Given this list of marker genes Spon2, Mre11a, Atg5, Sfn, Trim30d, Serpinb1a, Ifit3, F2rl1, Gm4841, Ifnk, Fosl1, Ccl20, Il23a, Dapk1, Trim28 (tripartite motif-containing 28), Rnf170, Nploc4 (NPL4 homolog, ubiquitin recognition factor), Fgb, Lgr4, Gkn2, Ciita, H2-M3, Csf1, Cyld, Lats2, Defb2 (NCBI Gene Id 13215), Trim12a, Stx8, Traf4, Casp4, Oas1f, Ccl21a, Ly9, Defa3, Ifitm2, Oas1e, Cnpy3, Trp53, Gm13277, Pim1, Ifi203-ps, Slamf1, Cd2, Gzmc, Cited1, Reg2, Fpr-rs6, Gm12250, Ighg2c, Ighg1, Ifit3b, Defa25, Vamp8 (vesicle-associated membrane protein 8), Serping1, Cd300ld3, S100a9, Rpl30, Dus2, Fpr-rs4, Klrb1, Ccl12, Calhm6, Phb1, Rel, Klrh1, Mapkapk2, Vip, Dpp4, Wfdc13, H60b, Was, Aqp4, Cdc42, Adar, Stxbp4, Trim8, Stxbp1, 9930111J21Rik1, Hmgb3, C1qb, Ifna1, C9, Wfdc21, Trim30a, Esr1, Actg1 (NCBI Gene Id 230535), Aim2, Cd160, Ifnl2, Map4k2, Nr1h3, Mcoln2 (NCBI Gene Id 99673), Ifna7, Il17f, Pld4, Il18rap, Tlr12, Ifi211, Serpinb9, Mul1, Tspan6, Nlrp10, Trim39, Stx4a, Kif5b, Rnf185, Sertad3, Cgas, Slc15a3, Lyar, Ube2l6, Rnf19b, Mx1, Trim62 (NCBI Gene Id 67525), Fasl, Neurl3, Myd88, Defb21, Klri1, Hc, Bpifb1, Cd300c, Dnaja3, Il33, Tmem33, Defb20, Trim38, Defb37, Ube2k, Ythdf3, Trim56, Sin3a, Ly86, Ifnab, Adam8, Defa5, Reg3d, Colec10, Rpl39, Stat5b, Slc19a1, Raet1d, Rnf39, Plscr1, Bcl3, Trim6 (tripartite motif-containing 6), Cd55b, Plcg2, Ccl19-ps1, Ifi205, Med1 (mediator complex subunit 1), Oas1d, Defa30, Trim31, Trim12c, Hmgn2, Slpi (NCBI Gene Id 20568), Gapdh-ps15, Sh2d1b2, Jak3, Slc30a8, H60c, Isg20, Defa23, Ubl7, Cadm1, Irgm2, Padi4, Defa34, Ang5, Akap8, Hk1, Tnfsf4, Ripk2, Inava (innate immunity activator), Nlrc3, Rnase2a, Lgals9, Evpl, Defa26, Rnf115, Serpinb9g, Ear14, Lats1, Gper1, Klrk1, Unc13d, Gm5849, Ccl2, Ifna11, Daxx, Nlrp9a, Ighm, Otop1, Slc15a4, Wfdc15b, Raet1e, Tirap, Ifi47, Rtn4, Tslp, Nlrp6, Appl2, Ap3b1, Pglyrp3, Irf8, Sdhaf4, Lyn, Pspc1, Tyrobp, Gm5431, Kctd9, Arg2, Oas3 (NCBI Gene Id 246727), Dhx58, Txk, Ifi208, Tlr9, Wfdc3, Bpifa1, Ptpn6, Ccl27al, Polr3h, Bspry (B-box and SPRY domain containing), Wfdc12, Cd177, Ifng (NCBI Gene Id 15978), Krt16, Trim25 (tripartite motif-containing 25), Pik3ap1, Ccl26, Slc15a2, Cebpg, Ang2, Trim15, Rarres2, Oas1b (NCBI Gene Id 23961), Cxcl9, Rfpl4, Defb40, Gramd4, Plpp6, Otulin, Rsad2, Sfpq, Clec4d, Gfi1, Rab2b, Trim43b, Ifna12, Pik3cd, Siglecg, Vamp4, Krt6a, Cybc1, Zdhhc9 (NCBI Gene Id 208884), Defa2, Setd2, Oasl1, Defb22, Gm13272, Atat1, Wfdc11, Tnfrsf14, Igf2, Ifnlr1, Rnf34, Smim30, Fga, Klrc2, Defb8, Calm1, Cd274 (NCBI Gene Id 60533), Clnk, Ipo7, Dhx33, Rnaset2a, Kynu, Tbkbp1, Gbp8, Trim75, C1rl, Akirin2, Clpb (ClpB caseinolytic peptidase B), Cyba (NCBI Gene Id 13057), C2, Peli3, Mst1r, Fgg, Rnase4, Rad50, Pla2g6, Irf1, Pqbp1, Ddx1, Romo1, Trim30c, Krt1, Letmd1, Crp, Tbk1, Usp29, Gbp3, Gimap3, Hspd1, Cxcl11, Defb39, Csnk1a1, Kng1, Evl, Cxcl5, Bpifa5, Defa42, Ifna2, Clec4n, Nck1, Hexim1, Usp50, Ppp2r3c, Ccl11, Mid2, Bpi, Usp17le, Phb2, Cstdc2, Trim41, Il21, Gzmb, Lrrc14, Cpt1a, Tlr1, Vnn1, Gpr146, Tmem43, Vamp3, Nlrp1a, Ctsg, Naip6, Erbin, Gm13271, Trim61, Lrch4, Serpinb9d (NCBI Gene Id 20726), Cd300e, Sftpd, Pla2g2f, C1s1, Nfkbiz (nuclear factor of kappa light polypeptide gene enhancer in B cells inhibitor, zeta), Klk7, Ifngr2, Ear2, Gimap5, Zdhhc12, Hmgb2, Atg14, Ttll12, Pglyrp4, Sp110, Nod2, Fadd, Matr3, Nfkbia, Ilrun (NCBI Gene Id 98074), Defb42, Polr3g, Lsm14a, Brcc3, Gapdhrt, Xcl1, Otud4, Nlrp9c, Arid5a, Defb11, Csf1r, Defb1 (defensin beta 1), Edn1, Nlrc4 (NCBI Gene Id 271473), Hrg, Mpeg1, Gp2 (glycoprotein 2 zymogen granule membrane), Cfhr4, Rnf135 (ring finger protein 135), Zdhhc3, Rnase6, Pf4, Defa31, Ifi206, Tab1, Dtx3l, Ipo5, Ywhaz, Cd1d2, Vim, Gbp2, Rab43, Tfeb, Lag3, Apobec3, Gimap6, Slc11a1, Mmp7 (NCBI Gene Id 17393), Ighg2b, Samhd1, Hsp90aa1, Gdi1, Nos2, Polr3d, Trim68, Ifna6, Abhd17a, Ccl19-ps5, Mst1, Cfh, Tgfb1, Tlr2, Sp100, Mavs, Banf1, Ffar2, Cdc37, Spi1 (Spi-1 proto-oncogene), Trim30b, Trf, Mapk8, Ptpn22, Cldn2, Srebf1, Defa29, Sqstm1, Trim55, Kcnj8, Slamf8, Kif16b, Ifne, Trim26, Nlrc5, Grb2, Lep, Usp20, Tnfaip8l2, Reg3b, Nppb, Gm12185, Mill1, Tlr11, Hamp2 (NCBI Gene Id 66438), Zfp809, Cdc42ep4, Fau, Lacc1, Leap2 (NCBI Gene Id 259301), Masp1, Kcnk13, Rasgrp1, Nts, Fcer1g, Serpinb9e, Susd4, Zbp1, Hdac4, Cxcl12, Endod1, Ticam2, Cd226, Tac1, Chuk, Rnf144a, Ccl19-ps4, Defb29, Trim32, Stxbp3, Pik3r1 (phosphoinositide-3-kinase regulatory subunit 1), Ogt, Riok3 (RIO kinase 3), Eprs1, Gbp9, Trim43a, Ccl5, Traf3ip3, Irf2 (interferon regulatory factor 2), Cfd, Calcoco2, AY761185, C1qa, Trim58, C4bp, Hcfc2 (host cell factor C2), Prdm1, Cd74, Capg, Ddx60, Tlr4, Myo1f, Cd36, Parp14, Defa39, Trim11 (tripartite motif-containing 11), Mif, Cactin, Ifna16, Ifi209, Il36rn, Stxbp2, Defb30, Wfdc2, Grn, Rnase2b, Trim14, Oas1h, Wfdc10, Atg7, Ang4, Hcst, Colec12, Clec5a, Spag11a, Shmt2, Pparg, Arrb2, Scnn1b, Rasgrp4, Gapdhrt2, Fpr2, Dapk3, Mx2, Serpinb9h, Ighe, Gapdh, Kat5, Pdpk1, Mefv, Adm, Spag11b, Pglyrp1, Lrp8, Trim40, Slc22a5, Bpifc, Ifna4, Calm3, Cd47, Clec12b, Fcna, Zdhhc1, Smpdl3b, Ccl27b, Nmb, Mettl3, Adam15, Eif4e2, Defb15, Nono, Ccl21d, C8a, Clec4a2, Wfdc16, Serinc5, Wfdc18, Rab11fip2, Brcc3dc, Trim52, Gata3, S100a8, Ubqln1, Axl, Il1rap (interleukin 1 receptor accessory protein), Ccl7, Gm15441, Il36g, Prkd1, Ass1, Tril, Pvr, Tlr6, Trim50, Jak2, Btk, Lamp2, Rpsa, Cd55, Mbl2, Atg12, Gbp2b, Il1rl2, Ccl25 (NCBI Gene Id 320542), Trim17, Rab7b, Ccr1, Tmeff1, Rnaset2b (NCBI Gene Id 98070), Gbp5, Marchf2, Apoe, Nmbr, Serpinb9b, Ccl28, Fcgr4, Polr3c, Tusc2, Tlr5, Gsdmd, Polr3e, Shfl, Hmgn2-ps, Mrc1, Casp1, Irf5, Zcchc3, Ccl21f, Tkfc, Cx3cl1, Trim72, Adgrb1, Ccdc134, Nfkbil1, Cd244a, Slc22a21, Usp18, C1s2, Tnip3, Klrb1f, Il36b, Sh2d1b1, Tlr7, Atg9a, Masp2, Gm13283, Itch, Inhca, Casp6, Pik3r6, Nkg7, Rela, Aif1, Appl1, Nedd4, Spsb3, Gbp10, Clec7a, Syk, Hamp, Tyro3, Arf6, Tarm1, Ulbp3, Bcl10, App, Cyp27b1, B2m, Slc46a2, Wdfy1, Jchain, Il27, Bst2, Cd84, Znrf1, Trim13, Scimp, Ppp1r14bl, Galp, Lcn2, Pycard, Rigi (RNA sensor RIG-I), Cldn1 (claudin 1), Ccdc92, Defa38, Camp, C8g, Mapkapk3, Trim29, Pld3 (phospholipase D family member 3), Ifnar2, Ccl6, Il17ra, Trim5, Ubd, Ppp1r14b (NCBI Gene Id 18938), Aurkb, Ankhd1, N4bp3, Hpx, Ifnar1, Hspa8, Arl8b, Lamp1, Dab2ip, Trem3, Prkra, Wnt5a, Wfdc15a (WAP four-disulfide core domain 15A), Defb35, Morc3, Dhx36, Xrcc6, Ighg3, Rps6ka3, Becn1, Anxa1, Alpk1, Clec4a4, Colec11, Wap, Cfb, Il34, Cxcl14, A2m, Uba7, U90926, Tax1bp1, Ddx39a (NCBI Gene Id 68278), Defb9, Rps6kb1, Ube2w, Vav1, Cr2, Dusp10, Ceacam1, Cep63, H2bc12, Irgm1, Slk, Ifnl3, Klrg1, Gpatch3, Sprr2a1, Atad3a, Cst9, Gbp7, Usp27x, Stx11, Ncf1, Hvcn1, Ifna9, Nqo1, Tnip2, Fgr, Nlrp3, Naip2, Defb18, Irf7, Defb34, Crk, Pomc, Zdhhc5, F830016B08Rik (NCBI Gene Id 240328), Optn, Trim35, Casp8, Tasl, Isg15, Actr2, Nfe2l2, Elp6, Nfkb1, Stat1, Tnip1, Inpp5d, Tollip, Crtam, Gm13276, Tmem126a, Triml2, Ifitm7, Usp38, Klk5, Ankrd17, Nagk, Ticam1, Peli1, Gps2, Slc26a6, Usp14, Trem1, Usp44, Reg3g, G3bp1, Defb25, Ube2n, Lgals3, Tgtp2, Polr3f, Fcgr1, Cxcl10, Nlrp4b, Ssc5d, Tifab, Fcnb, Kng2, Mark4, Cxcl1, Ppbp, Igha, Klrc1 (NCBI Gene Id 16641), Camk2a, Traf2, Oas1c, Cybb, Ecsit, Nectin4, Ifngr1, Defb19, Card9, Smpdl3a, Tmem120a, Mmp12, Stmp1, S100a14, Adamts13, Defa17, Trem2, Cd86, Herc6, Ang6, F2, Pum2, Pstpip1, Triml1, Cfi, N4bp1, Defa22, Vps26b, D1Pas1, Trim65, Lyplal1, Serpinb9c, Tlr13, Trim69, Stat2, Ythdf2, C1rb, C8b, Stat5a, Polr3a, Il12b (interleukin 12b), Sting1, Epg5, Cd24a, Marco, Oas2, Rb1cc1, Slamf6, Klre1, Umod, Defa35, Ifnz, Hck, Nod1, Ccl9, Tlr3, Tap2, Gata6, Tap1, Ppp6c, Cd1d1, Akt1, Pcbp2, Defa28, Fosl2 (fos-like antigen 2), Ptprs, Sec14l1 (NCBI Gene Id 74136, SEC14-like lipid binding 1), Defa20, Coro1a, H2bc21 (H2B clustered histone 21), Ereg, Src, Ccl24, Trim10, Ccl21e, Trim7, Hspa1b, Cd180, Ivl, Elane, Defb10, Defb43, Smarca5, Relb, Ear1, Lrrc19, Ifi27l2b, Parp1 (poly (ADP-ribose) polymerase family, member 1), Lrrd1, Ptx3, Ccl3, Zdhhc11 (NCBI Gene Id 71164), Washc4, Cd300a, Sirpa, Snca, Npy, Wrnip1, Ang (NCBI Gene Id 11727), Zfp683, Ifna5, Iigp1c, Pja2, Skp2, Star, Il36a, Rbm14, Prdx1, Defb41, Ifih1, Il18, Klrb1a, Fbxo9, Tomm70a, Smpd1, G3bp2, Trim54, Syncrip, Zc3hav1, Polr3k, Chid1 (chitinase domain containing 1), Jak1, Gbp6, Ltf, Ins1, Defa21, Tnf, Ifna13, Polr3b, Ifna14, Clec2d, Ifitm1, Arg1, Oas1a (NCBI Gene Id 246730), Tmem45b, Ccl19-ps6, Mir511, Slamf7, Zyx, Serinc3, Nectin2, Znrf4, Fpr-rs3, Lrrfip2, Malt1, Rftn1, Irak1, Prkce, Iigp1, Pla2g1b, Lgals4, Flnb, Klrb1b, H2-T23, Pde12, Nop53, Znfx1, Klrd1, Clec4b1, Rbm47, Gm13275, Nmi, Ccl17, C1qbp, Ndufs4, Cxcl15, Cd96, Il12a, Eif2ak2, Ccl1, Ifit2, Myo1c, Plekhm2, Ly6e, Defb12, Dtx4, Cxcl16, Aars2, Defa24, Clec4e, Gfer, Ulbp1, Irf3, Dao, Ifi35, Trim34a, Wfdc9, Rab12, Lcn10, Nlrp4f (NCBI Gene Id 97895), Ncr3-ps, Trim27, Xrcc5, Lbp, Ptgs2os, Nr1h4, Klrc3, Traf3 (TNF receptor-associated factor 3), Lrrc15, Pik3cb, Ifi213, Ear6, Ear10, Defb38, Tnfaip3, Zdhhc18, Igtp, Fam3a (FAM3 metabolism regulating signaling molecule A), Muc19, Gbp4, Acod1, Cd300c2, Ppl, Klrb1c, Reg1, Akap1, Actr3, Irak4, Uap1, Zdhhc4, Ccl27a, Trim3, Nlrp9b, Trafd1, Atl3, Cdc42ep2, Rnf125, Oas1g, Pla2g5, Irak2, Snx3, Crcp, Trim43c, Ifna15, Map3k7, Ppp2ca, Traf6, Tmem106a, Defa37, Garin5a, Dcst1, Parp9, Nr1d1, Mndal, Defa41, Naglu, Nek7, C3, Ifnb1, Sarm1, Nlrx1, Il4, Atl2 (atlastin GTPase 2), Rnf166, Dhx9, Mfhas1, Trim21, Ifitm3, Defb36 (defensin beta 36), Naip5, Tarbp2, Reg3a, Cd14, Clec4b2, Ttc4 (NCBI Gene Id 72354), H2-Q7, Map3k5, Mbl1, Nlrp4a, Rab11fip5, Zg16, Cav1, Cnot7, Ifi204 (interferon activated gene 204), Zbtb1 (NCBI Gene Id 328127), Apcs, C1ra, Ddx21, Prkdc, Tyk2 (tyrosine kinase 2), Lyst (lysosomal trafficking regulator), Serpinb9f, Trex1, Sh2d1a, Senp7, Nbn, Pml, Gigyf2, Msrb1, Epsti1, Dhx15, Cfp, Vsig4, Pgc, Trim60, Cptp, Mptx1, Drd2, Ppt1, Fpr-rs7, Ifi203, Ptpn2, Usp15, Cr1l, Il17a, Ifi214, Mptx2, Ccl21b, Gzmn, Apoa4, Clec4a1, Myo18a, Tlr8, Cx3cr1, Ins2, Il23r, Pum1, Trim59, Fbxl2, Calm2, Treml4, Cxcl13, Nlrp4c, Gsn, Dmbt1, Ninj1, Nlrp4e, Ccl19, Clec4a3, Rps19, Apol11a, Ccl19-ps3, Mr1, Ly96, Irak3, Tgtp1, Ccl22, Nrros, P2rx7, Dhx16, Sirt2, Ifitm6, Havcr2, Unc93b1, Ch25h, Defa40 (defensin, alpha, 40), Ifit1, Il12rb1, Ddx3x, Flot1, Ywhae, Wfdc5, Pcyox1l, Trim44, Hmgb1, Trim34b, Ifi207, Ccl4, Gpr108, Rab27a, Ccl8, Oasl2, Xiap, Irf4, Trim63, Nlrp1b, Rpl13a, Rab20, Wfdc17, Mmp3, Arhgef2 (Rho/Rac guanine nucleotide exchange factor 2), Klri2, Ap1g1, Tifa, Gch1, Cd300lf, C1qc (NCBI Gene Id 12262), Ufd1, C4b, Ikbke, here is a description of the gene set: studied in species Mus musculus Reactions triggered in response to the presence of a symbiont that act to protect or prevent damage to the host. Mouse Gene Set: GOBP_DEFENSE_RESPONSE_TO_SYMBIONT